Given this list of marker genes ATP5F1B, SUCLG2 (succinate-CoA ligase GDP-forming subunit beta), NDUFV1, PDK1, HSPA9, MICU2, PDHA1, NDUFA13, CS, ME2, PDHB, TIMM22, ALDH1B1 (aldehyde dehydrogenase 1 family member B1), BDH1, ACOT2, STAR, TRIAP1, YME1L1 (YME1 like 1 ATPase), NDUFS1, ACAD8, MT-ND6, COX4I1, ARG2, OMA1, NDUFS3, CLPP, SLC25A6, ALDH18A1, NDUFA2 (NADH:ubiquinone oxidoreductase subunit A2), PRELID1, LDHD, ACADSB, ECH1, ALAS1, LONP1, TWNK, PCCB, GLUD1, MT-ND2, MRPL32, HSPD1, ATP5PD, PMPCA, ALDH2, HTRA2, NDUFB6, MRPL12, MT-ATP6, STARD7, ECI1, UQCRC2, ACAT1, UQCRQ, IDH2, MRPS10 (mitochondrial ribosomal protein S10, NCBI Gene Id 95834), DBT, FH, IARS2, SHMT2, OXCT1, ATP5PO, TIMM17A, TFAM, DLD, TIMM10 (translocase of inner mitochondrial membrane 10), ATP5MG, IDH3A, HSD17B10, MDH2, HMGCS2, ATP5F1A, CHCHD2, PRKACA, MT-ND1, COX5A, COX5B, SMDT1, TIMM9, NADK2, NDUFV3, MT-ND5, ATP5F1C, OPA1, HADH (hydroxyacyl-CoA dehydrogenase), OGDH, OXSM, ATP5PF (NCBI Gene Id 63498), ACO2, CLPX, MRPS2, MT-CO1, AFG3L2 (AFG3 like matrix AAA peptidase subunit 2), SPG7, SLC25A5, MT-CO2, FECH, APP, SSBP1, here is a description of the gene set: Reactome Pathway: Mitochondrial protein degradation part of: Metabolism of proteins studied in species Homo sapiens Mitochondrial proteases participate in proteostasis, the regulation of proteins to maintain a functional proteome, by degrading unfolded, unassembled, and oxidatively damaged proteins. Degradation of mitochondrial proteins by proteases also serves to regulate transcription by TFAM, oxidative phosphorylation by electron carriers, lipid translocation by PRELID1 and STARD7, and mitochondrial fission and fusion by OPA1 and OMA1. Because of the bacterial origin of mitochondria, they contain a number of bacterial type proteases, including LONP1 in the matrix, CLPP:CLPX (CLPXP) in the matrix, HTRA2 (OMI) in the intermembrane space, AFG3L2 in the mitochondrial inner membrane and protruding into the matrix, and YME1L1 in the mitochondrial inner membrane and protruding into the intermembrane space.<br>The hexameric LONP1 complex, which is homologous to Lon proteases of eubacteria such as E. coli, binds substrate proteins in the matrix and inner membrane, unfolds them in an ATP-dependent mechanism, and degrades them. LONP1 also acts as an ATP-dependent chaperone that is independent of its protease function.<br>Like LONP1, the CLPXP complex unfolds matrix proteins in an ATP-dependent reaction and degrades them, however, the ATPase/unfolding function and the protease function are performed by separate subunits, with CLPX hexamers unfolding substrate proteins and translocating them to CLPP tetradecamers for processive degradation.<br>AFG3L2 (m-AAA+) forms either homohexamers or heterohexamers with its paralog SPG7 (Paraplegin) that are anchored in the mitochondrial inner membrane and protrude into the matrix. The substrate protein enters the central channel formed by the ATPase domains of AFG3L2 and is unfolded and translocated to the pore formed by the protease domains, where it is degraded (reviewed inZhang and Mao 2020). <br>Like AFG3L2, YME1L1 (YME1L, i-AAA+) is a homohexameric complex that is anchored in the mitochondrial inner membrane, however, YME1L1 protrudes into the intermembrane space where it unfolds substrate proteins of the intermembrane space and inner membrane in an ATP-dependent reaction and then degrades them.<br>HTRA2 (OMI) forms soluble trimeric complexes in the intermembrane space that degrade substrate proteins, notably amyloid precursor proteins that are translocated to the intermembrane space and inner membrane. HTRA2 released from mitochondria into the cytosol also participates in regulating apoptosis.<br>Mutations in mitochondrial proteases cause diseases, such as spastic paraplegia (SPG7), ataxia (AFG3L2), and Parkinson's Disease (HTRA2), that typically have neurological symptoms among others.